Given this list of marker genes GLRX5, KIF1C, MTPAP, TUBB3, SPG7, ATP5F1A (NCBI Gene Id 502), VAMP1, LRP4, GDAP2, PRDM8, MARS2, SACS, AFG3L2, TBCE, TANC2, CAPN1, CACNA1G, HTRA1, DARS2, MMADHC, here is a description of the gene set: studied in species Homo sapiens Spastic ataxia Human Gene Set: HP_SPASTIC_ATAXIA